The following is a description of a gene set: Any process that activates or increases the frequency, rate or extent of potassium ion transmembrane transporter activity. Human Gene Set: GOBP_POSITIVE_REGULATION_OF_POTASSIUM_ION_TRANSMEMBRANE_TRANSPORTER_ACTIVITY studied in species Homo sapiens, and this is the list of marker genes: GALR2, LRRC26, GAL, LRRC38, LRRC55, LRRC52